Given this list of marker genes TNFAIP3, IFNG, EFL1, STX11, BTD, PTPRC, STXBP2, BANK1, TEK, SYK, TOP3A, BLK, RFX5, IL2RG, IL6, IL1RN, ADA2 (adenosine deaminase 2), SPTA1, PXK, MAP2K1, MEFV, RUNX1, CLTRN, STAT3, USB1, SLC4A1, LPIN2 (lipin 2), JAK3, CD79B, ERCC2, NOD2, SPP1, ASXL1, PIK3R1, POMP, IKBKG, TNFRSF1A, SAT1, IGHM, OTULIN, NLRP3, RFXAP, LRRC8A, NCF1, SPTB, TNIP1, SDHC, MIF, C1QB, ARHGEF2, IL10 (NCBI Gene Id 3586), SRSF2, TCF3, CIITA, IRF1, CYBB, GJA1, PRTN3, IRAK1, ADA, MECP2, TNFRSF1B, IL17RC, PSTPIP1, SDHB, RELB, ABCB11, CIC, DCLRE1C, NAXD, CBS, C4A, STING1, NR1H4, KDSR, ITGAM, IGLL1, CBL, HLCS, IRF5, DOCK11, ERCC4, BLM, CYBA, PTPN22, PRF1 (perforin 1, NCBI Gene Id 5551), PSMB4, DNAJC21, CR2, ARPC1B, STAT4, HLA-DPA1, ABCB4, TET2, COL6A1, LEMD3, GJB3, CD79A, TBK1, BTK (NCBI Gene Id 695), KIT, MVK, AK2, BRAF, TNFSF4 (NCBI Gene Id 7292), CASP10, C4B, FCGR3B, TLR7, UBE2L3, CLEC7A, PSMB10, ERCC3, DNASE1, C1QC, CDK10, NLRC4, IGHG2, RAG1, IL17F, SPI1, ETS1, ZAP70, PSMB9, GJB4, FCGR2A, ZNFX1, SLC6A19, LYST, COX4I2, RIPK1, HLA-DPB1, RFXANK, RAG2, ELF4, IGHG1, LCP2, ATP8B1, FCGR2B, TREX1, SBDS, BLNK, IL17RA (NCBI Gene Id 23765), LACC1, ACP5, ANK1, CD28, HLA-B, PDGFRA, HLA-DRB1, TRAF3IP2, LBR, IGKC, SPINK5, KIAA0319L, NRAS, SDHA, LMBRD1, DNASE1L3, PDCD1, ERCC5, NLRP12, SMARCAD1, SLC39A7, UNC13D, EPB42, BTNL2, MALT1 (MALT1 paracaspase), FGA, JAZF1, NCF2 (neutrophil cytosolic factor 2), CTLA4, IFIH1, here is a description of the gene set: Skin rash Human Gene Set: HP_SKIN_RASH A red eruption of the skin. species: Homo sapiens